Given this list of marker genes AKT1, PDK1, EPHB2, PIK3CB, LTB4R, CMKLR1, PIK3CA, FPR2, PIK3CG, MTOR, GRK1, PIK3CD, here is a description of the gene set: Resolvin E1 and resolvin D1 signaling decrease inflammation Human Gene Set: WP_RESOLVIN_E1_AND_RESOLVIN_D1_SIGNALING_DECREASE_INFLAMMATION species: Homo sapiens